The following is a description of a gene set: The series of molecular signals initiated by a ligand binding to an insulin-like growth factor receptor on the surface of a target cell, and ending with the regulation of a downstream cellular process, e.g. transcription. Human Gene Set: GOBP_INSULIN_LIKE_GROWTH_FACTOR_RECEPTOR_SIGNALING_PATHWAY studied in species Homo sapiens, and this is the list of marker genes: MYORG, IRS2, ATXN1, INPPL1, MIR1-1, MAP2K1, GIGYF2, SHC1, NKX3-1, CILP, GHR, GHRHR, PLCB1 (NCBI Gene Id 23236), ERCC1, GH1, PHIP, SOS1, IGF2, IGFBP5, AKT1, MAPK1, MAP2K2, IGFBP3, ZFAND2B, BMP5, WNT1, EIF2AK3, IGFBP1 (NCBI Gene Id 3484), IGF1, GHSR, RAF1 (Raf-1 proto-oncogene, serine/threonine kinase), IRS1, COL6A1, MAPK3, IGF1R, CDH3, IGFBP4, IGFBP2, MIR29C, GRB10, IGF2R, MAP2K5, PDPK1, GIGYF1, AR, PIK3R1, ERCC2, PIK3CA, TRIM72, GRB2, CRIM1, GHRH, BMP2, IGFBP6